Given this list of marker genes MRPS14, ARHGDIA, BNIP2, OXCT1, RAD17, F5, IFT22 (intraflagellar transport 22), PDE7B, MLLT10, MRPL47, PSMB5, CRCP, BRAP (NCBI Gene Id 8315), ANLN, RAB40C, WBP1L, STK38, PTCD2, UBE2I, TP53BP1, RABGGTB, OSTC, GPR35, RNF20, SIRT7, NDUFAF1, SLC1A5, RAB2B, DNPEP, TMEM128, ARL6IP1, CPEB1, SRP14, PAPSS1, ATP6V0B, ATP6V1B2, ABHD17A, CSNK1G2, KIF1B, HLA-C, COA5, RAB14, WDR33, SLC9A1, CLIP1, SMC3, RAF1, HNRNPUL2, CAPZA1, MARCHF6, GPRC6A, GUK1, DERL1, MAPK9, RAP1GDS1, ECHS1, SNX17, PIN1, SERP1, FLT1, SLC25A47, UBR3, FAM193B, GPANK1, ASCC2, LAMB2, ETAA1, TMA16, GATA1, TOP3A, DHX57, ANKMY2, PTGIR, TFEB, ATP6V0E1, SACS, TRMT10C, NIP7, PURA, RBPMS2, SYPL1, ZC3HC1, MED1, ZDHHC7 (zinc finger DHHC-type palmitoyltransferase 7), KCNK13, VOPP1, EDEM3, CDC42SE1, NCKAP1L, ARMT1, HPF1, TOR3A, DOK2, SURF6, USP39, VPS39, CMPK1, CLPX, SF3A1, HTR1F, GGPS1, CCNI, CHMP7, TMED3, MGAT2, NEK9, ARF3, PITHD1, PPM1G, FKBP8 (FKBP prolyl isomerase 8), MTFR1, NDUFS2, KLHL2, MYH4, EXOC4, KLHL7, CBFA2T2, NGRN, PWP2, TMEM9B, GLCE, TEFM, MED22, NONO, PPP1R14B (protein phosphatase 1 regulatory inhibitor subunit 14B), UBP1, PBXIP1, MORC3, CHMP1A, POLR3A, RBM19, TMED7, AP5S1, CIAO3, KLF16, LAMTOR1, PDCD6, PLEKHA2, GDAP2, MFN2, GADD45A, TMEM184C (NCBI Gene Id 55751), C1D, MYO1H, CNR2, LAT2, SEC16A, MTMR10, GSAP, PPBP, KRT5, TOMM6, RIOK3, PDS5A, CRAMP1, ATP5PF (NCBI Gene Id 63498), INPP5D, NUDT3, PLD1, DNAJC12, IGDCC3, OSGEP, S100A1, VDAC3, RREB1, ISCA2, ST6GALNAC6, IER3, UBE3A, DESI2, APLP2, NAA30, PREB, ZDHHC12, C1QTNF12, ABL1, NDUFA7, IRAK1BP1, ZNF526, HMGXB4, TOX, HES6, PYROXD1, SRP9, RMND5B, LGR6, MEPCE, HSBP1, TSEN15, ADGRE5 (adhesion G protein-coupled receptor E5), TNNI3, NOSIP, AEN, POLE3, COA6, HIKESHI, DNAJC30, ANGEL2, SARAF, ORMDL2, here is a description of the gene set: mouse primary BMDCs were stimulated with tlr ligands and gene expression changes were profiled on Affymetrix arrays from publication Amit I, Garber M, Chevrier N, Leite AP, Donner Y, Eisenhaure T, Guttman M, Grenier JK, Li W, Zuk O, Schubert LA, Birditt B, Shay T, Goren A, Zhang X, Smith Z, Deering R, McDonald RC, Cabili M, Bernstein BE, Rinn JL, Meissner A, Root DE, Hacohen N, Regev A (PMID 19729616) Genes down-regulated in comparison of dendritic cells (DC) stimulated with LPS (TLR4 agonist) at 2 h versus DC cells stimulated with Gardiquimod (TLR7 agonist) at 2 h. studied in species Homo sapiens Human Gene Set: GSE17721_LPS_VS_GARDIQUIMOD_2H_BMDC_DN